The following is a description of a gene set: species: Homo sapiens Expression of estrogen-related receptor alpha (ERRalpha) has recently been shown to carry negative prognostic significance in breast and ovarian cancers. The specific role of this orphan nuclear receptor in tumor growth and progression, however, is yet to be fully understood. The significant homology between estrogen receptor alpha (ERalpha) and ERRalpha initially suggested that these receptors may have similar transcriptional targets. Using the well-characterized ERalpha-positive MCF-7 breast cancer cell line, we sought to gain a genome-wide picture of ERalpha-ERRalpha cross-talk using an unbiased microarray approach. In addition to generating a host of novel ERRalpha target genes, this study yielded the surprising result that most ERRalpha-regulated genes are unrelated to estrogen signaling. The relatively small number of genes regulated by both ERalpha and ERRalpha led us to expand our study to the more aggressive and less clinically treatable ERalpha-negative class of breast cancers. In this setting, we found that ERRalpha expression is required for the basal level of expression of many known and novel ERRalpha target genes. Introduction of a small interfering RNA directed to ERRalpha into the highly aggressive breast carcinoma MDA-MB-231 cell line dramatically reduced the migratory potential of these cells. Although stable knockdown of ERRalpha expression in MDA-MB-231 cells had no effect on in vitro cell proliferation, a significant reduction of tumor growth rate was observed when these cells were implanted as xenografts. Our results confirm a role for ERRalpha in breast cancer growth and highlight it as a potential therapeutic target for estrogen receptor-negative breast cancer. Genes down-regulated by estradiol and down-regulated by ESRRA in MCF-7 cells (breast cancer). from publication Stein RA, Chang CY, Kazmin DA, Way J, Schroeder T, Wergin M, Dewhirst MW, McDonnell DP (PMID 18974123) Human Gene Set: STEIN_ESRRA_TARGETS_RESPONSIVE_TO_ESTROGEN_DN, and this is the list of marker genes: MICB, GINS2, ASPH, SLC27A2, RAB31, PCNA, OLFM1, RRM1, FEN1, MANEA (NCBI Gene Id 79694), CELSR2, MYOF, NAB2, SKP2, TMPO, MCM10 (NCBI Gene Id 55388), NCAPG2, SMC4, CDC6, NEMP1, PAPSS2, POLE2, SACS, MCM2, ATAD2, SOX3, PRSS23, WDHD1, CDC25A, DTL, CHRNA5, MCM6, GINS3, CCNE2, CAP2, BTG3, ULK1, ZWILCH (NCBI Gene Id 55055), MCM5, CENPU, RAI14